The following is a description of a gene set: Cluster 5: genes whose up-regulation peaked 5 days after knockdown of OPN by RNAi in the NIH3T3 cells (fibroblasts) transformed by activated HRAS. Human Gene Set: TERAMOTO_OPN_TARGETS_CLUSTER_5 from publication Teramoto H, Castellone MD, Malek RL, Letwin N, Frank B, Gutkind JS, Lee NH (PMID 15516973) Activated forms of Ras family members are prevalent in many cancers where Ras mutants transduce signals essential for transformation, angiogenesis, invasion and metastasis. As a cancer progression model, we used NIH3T3 cells to explore the mechanism of Ras-induced tumorigenesis. Ras family mutants H-RasV12 and Rit79L strongly induced foci formation, while Rho family mutants RhoA-QL, Rac1-QL and Cdc42-QL were less effective. A comparison of downstream transcriptional targets of Ras and Rho family members using a 26 383 element cDNA microarray revealed that the osteopontin (OPN) gene exhibited the best correlation between magnitude of gene expression change and level of foci formation (r=0.96, P<0.001). In association with H-RasV12- and Rit79L-mediated transformation, foci secreted OPN protein and upregulated the OPN receptor CD44, suggesting the novel initiation of an aberrant OPN-CD44-Rac autocrine pathway. In support of this were the following observations. First, RGD-deficient OPN protein-binding activity was present in H-RasV12-transformed cells but not in control cells, and binding activity was inhibited by the CD44 blocking antibody. Second, foci formation, cell invasion and Rac activity were induced by H-RasV12 and inhibited by the CD44 blocking antibody. Third, foci formation by H-RasV12 was substantially reduced by a short interfering RNA (siRNA) specifically targeting OPN expression for knockdown. Fourth, H-RasV12-mediated transformation was not blocked by the GRGDS peptide, suggesting that OPN effects were not mediated by the integrins. Lastly, OPN knockdown affected the downstream expression of 160 '2nd tier' genes, and at least a subset of these genes appears to be involved in transformation. Indeed, four genes were selected for knockdown, each resulting in a disruption of foci formation and/or invasion. These results underscore the role of aberrant autocrine signaling and transcriptional networking during tumorigenesis. species: Mus musculus, and this is the list of marker genes: GIGYF2, WASHC3, SFT2D3, B3GALNT2, ILDR2, SNHG12, GON4L, STAB1